The following is a description of a gene set: part of: Interferon Signaling species: Homo sapiens Reactome Pathway: Interferon alpha/beta signaling Type I interferons (IFNs) are composed of various genes including IFN alpha (IFNA), beta (IFNB), omega, epsilon, and kappa. In humans the IFNA genes are composed of more than 13 subfamily genes, whereas there is only one IFNB gene. The large family of IFNA/B proteins all bind to a single receptor which is composed of two distinct chains: IFNAR1 and IFNAR2. The IFNA/B stimulation of the IFNA receptor complex leads to the formation of two transcriptional activator complexes: IFNA-activated-factor (AAF), which is a homodimer of STAT1 and IFN-stimulated gene factor 3 (ISGF3), which comprises STAT1, STAT2 and a member of the IRF family, IRF9/P48. AAF mediates activation of the IRF-1 gene by binding to GAS (IFNG-activated site), whereas ISGF3 activates several IFN-inducible genes including IRF3 and IRF7., and this is the list of marker genes: MX2, STAT1, IFNA7, IFNA17, PTPN1, ISG20, IFNAR1, PTPN6, IFI35, IFNA5, HLA-H, IFNA14, RSAD2, STAT2, GBP2, PSMB8, EGR1, HLA-A (NCBI Gene Id 3105), UBC, IFNA2, OAS1, HLA-C (NCBI Gene Id 5674), IFNA8, IFIT5, IFNA16, IFI6, TYK2, IFITM2, BST2, RNASEL, ABCE1, IFNA6, HLA-B, SOCS3, KPNA1, IFNA21, ADAR, IFNA4, HLA-G, IFNAR2, IRF3, HLA-E, HLA-F, SAMHD1, USP18, IRF7, UBA52, OASL, IFI27, IFNA1, PTPN11, OAS2, IFITM3, IFIT1, N, IFNB1, ISG15, IRF4, IRF8, IRF9, OAS3, IRF1, IFIT3, JAK1, IFIT2, IRF2, MX1, IRF5, SOCS1, KPNB1, RPS27A, IFNA10, IFITM1, XAF1, IRF6, IP6K2, EIF2AK2, UBB